The following is a description of a gene set: Translation elongation proceeds by cycles of aminoacyl-tRNAs binding, peptide bond formation, and displacement of deacylated tRNAs. In each cycle an aminoacyl-tRNA in a complex with TUFM:GTP (EF-Tu:GTP) binds a cognate codon at the A-site of the ribosome, GTP is hydrolyzed, and TUFM:GDP dissociates. The elongating polypeptide bonded to the tRNA at the P-site is transferred to the aminoacyl group at the A-site by peptide bond formation, leaving a deacylated tRNA at the P-site and the elongating polypeptide attached to the tRNA at the A-site. GFM1:GTP (EF-Gmt:GTP) binds, GTP is hydrolyzed, GFM1:GDP dissociates, and the ribosome translocates 3 nucleotides in the 3' direction, relocating the peptidyl-tRNA to the P-site and allowing another cycle to begin. Mitochondrial ribosomes associate with the inner membrane and polypeptides are co-translationally inserted into the membrane. TUFM:GDP is regenerated to TUFM:GTP by the guanine nucleotide exchange factor TSFM (EF-Ts, EF-TsMt). species: Homo sapiens part of: Mitochondrial translation Reactome Pathway: Mitochondrial translation elongation, and this is the list of marker genes: MRPL55, MRPS23, MRPS24, MRPL33, MRPL46, MRPS18B, MRPL35, MRPS27, MRPS7, MT-ND3, MRPL58, MRPL13, MT-CO3, MRPL53 (NCBI Gene Id 116540), MRPL9, MRPS26, MRPL43, GADD45GIP1, MRPS6, MRPL32, PTCD3, MRPS30, MRPS21, MRPS2, MRPL10, MT-ND4L, MT-ND1, MRPL38, KGD4, MT-ND2, MT-CYB, MT-TV, MRPS9, MRPL40, TSFM, MRPL39, MRPL2, MRPL50, MRPL20, MT-ND6, MRPS33, MT-ND4, MRPL44, MRPS10, MRPL3, MRPL54, MT-RNR1, MRPL12, TUFM, MRPL45, MRPL23, MRPS18A, MT-ND5, OXA1L, MRPL37, MRPL51, MRPS12, AURKAIP1, MRPL57, MRPL42 (mitochondrial ribosomal protein L42), MRPS28, MRPS22, MT-RNR2, MRPL19, MRPL47, MRPL1, MRPL28, MRPL27, MRPS31, MRPS16, MRPL48, MRPL21, MRPS5, MT-CO1, MT-ATP8, MRPS15, MRPL52, MRPL4, MRPL36, MRPS34, MRPL30 (NCBI Gene Id 64985), MT-CO2, MRPL18, MRPL24, MRPL41, MRPS11, MRPS17, DAP3, MRPL49, MRPL22, MT-ATP6, MRPL16, MRPS25, MRPL34, MRPL15, MRPL14, MRPL17, MRPL11, MRPS18C, ERAL1, CHCHD1, GFM1, MRPS35, MRPS14